Given this list of marker genes REN, ATP7B, SLC2A9, PYGM, TNFRSF11B, HNF1B, MUC1, MOCS2, HMGCL, NDUFAF6, PHKA2, MCFD2, SARS2, SLC37A4, SLC2A2, CTNS, OTC, ACAT1, PNP, GPHN, FBP1, PFKM, ALDOB, DPYS, ADRA2A, CLDN16, LMNA, MYC, SLC22A12, PPARG, LMAN1, TNFRSF11A, MOCS1, HNF4A, PHKB, XDH, SLC34A1, GATM, TYMP, PRPS1, ALMS1, G6PC1, UMOD, POLG (NCBI Gene Id 5428), SH2B1, EHHADH, MOCOS, SEC61A1, HPRT1 (hypoxanthine phosphoribosyltransferase 1), here is a description of the gene set: studied in species Homo sapiens An abnormality of a nucleobase metabolic process. Human Gene Set: HP_ABNORMAL_CIRCULATING_NUCLEOBASE_CONCENTRATION Abnormal circulating nucleobase concentration